The following is a description of a gene set: Mouse Gene Set: MIR_3091_3P species: Mus musculus from publication Chen Y, Wang X (PMID 31504780) Genes predicted to be targets of miRBase v22 microRNA mmu_miR_3091_3p in miRDB v6.0 with MirTarget v4 prediction scores > 80 (high confidence targets)., and this is the list of marker genes: Anks1, Ovol2, Rab43, Slc9a9, Nek6, Fam168a, Ppp1ca, Kcnd1, Acadvl, Mthfd1, E2f2, Lhfpl2, Arhgdia, Ppp2r1b, Spryd3, Cad, Sgcd, Rdh8, Btf3l4 (NCBI Gene Id 70533), Btbd9, Sema4g, Cnbp, Cntn2, Btn2a2, Endod1, Zer1, Irak1, Zfta, Lrrc41, Lamp5, Rrbp1, Gm14137, Spns1, Bsdc1, Nat8l, Zfp704, Zmym3, Mark2, Chtf8, Chad, Chd5, Tlr5, Lhfpl4, Lats1, Arhgef4, Ptprt